Given this list of marker genes S100a6, Hmgn2, Prdx5, Pgls, Akr1a1, Rpl8 (ribosomal protein L8), Eif3h, Psmd4, S100a8, Nop53, Ltf (NCBI Gene Id 94320), Rpl10a, Gnb1, Cox4i1, Tmsb10, Cfp, Rpl35, Fis1, Ypel3, Rps4x, H2-Aa, Eif3f, H2-Ab1, Cd74 (CD74 antigen (invariant polypeptide of major histocompatibility complex, class II antigen-associated)), Rps5, Ly6d, Rps19, Rps3a1, Rps3, Lcn2, Vim, Elob, Rpl6, Bsg, Cope, Rplp2, Hmgb1, Capzb (NCBI Gene Id 80668), Arhgdib, Cirbp (cold inducible RNA binding protein), Gpr25, Rpl18 (NCBI Gene Id 19899), Wfdc21, Chil3, Tecr, Sdhb, Hes6, Arpc1b, Rplp0, Ramp1, Ifitm2, Eif3k, Rpl13, Ubald1, Rps18, Lamtor4, Rpl7a, Psmc3, Uqcrc1, Arhgdia, Atp5f1c, Rpl4, Itgb7, Npc2 (NPC intracellular cholesterol transporter 2), Rbm3, Ngp, Gapdh, Macroh2a1, Klrd1, Atp5if1, Fth1, Selenow, Psmb8, Erp29, Sys1, Rpl14, Ap2s1, Raly, Cdkn2c, Snrpc, Capg, Napsa, Ndufs8, Clic1, Rps10, Tle5, Pkig, Rpl24, Cmtm7, Camp, Prr13 (proline rich 13), Irf8, S100a9, Ptprcap, Rpl32, Rps20, Psma7, Clta, Pfn1, Crip1, Fxyd5, S1pr4, Gng10, Tmsb4x, Rack1, Tbxa2r, Jchain, Cfl1 (NCBI Gene Id 12631), Rps7, Rpl11, Rps9, Rpl17, Rpl13a, Tspo, Ptma, Rpsa, AW112010, Ak2, Cox7a2l, Tmed9, Rps11, Spi1, Retnlg, Coro1a, Ostf1, Ubl7, Arpc3, Eef1b2, Elane, Selplg, Tmem254, Slpi, Rpl3, here is a description of the gene set: studied in species Mus musculus Mouse Gene Set: TABULA_MURIS_SENIS_MARROW_PRECURSOR_B_CELL_AGEING from publication Tabula Muris Consortium (PMID 32669714)